Given this list of marker genes Mcrs1, Polr1a, Glul, Tert, Nvl, Nmd3, Npm1, Cacnb4, Cdkn2a, Pinx1, here is a description of the gene set: Mouse Gene Set: GOBP_REGULATION_OF_PROTEIN_LOCALIZATION_TO_NUCLEOLUS species: Mus musculus Any process that modulates the frequency, rate or extent of protein localization to nucleolus.